Given this list of marker genes Slc16a1, Slc13a3, Slc25a10, Slc13a5, Slc13a2, here is a description of the gene set: The process in which succinate is transported across a membrane. studied in species Mus musculus Mouse Gene Set: GOBP_SUCCINATE_TRANSMEMBRANE_TRANSPORT